Given this list of marker genes SAE1, TESK2, PDCD2, HGFAC, RPS23, RFK, HOXD9, TUBA1A, RUNDC3B, IL27RA, CACYBP, CARD14, SNCAIP, FUZ, GPR173, CCDC51, DCHS2, KCNC4, FAM32A, OGFOD2, DHCR7, IGF2BP3, PPP1R14D, SLC34A1, TMEM59, TRAF3, ELOA2, INPP5J, APOB, MAP7, PDCD1LG2 (NCBI Gene Id 80380), GBA1LP, INTS11, KCNC1, SRPK3, CPN1, SH2D4A, CNNM1, B3GNT3, ERH, MAT1A, PLA2G4C, EDNRB, VDR, CFI, GZMH, GNPDA1, JUP, WDR82, MYH7, HYAL4, TRIM31, GARNL3, DIS3, ACSBG1, GNAL, WDHD1, HMGA2, OPLAH, IFITM2, HNF4G, BIRC7, RAB9A (NCBI Gene Id 9367), SMIM10L1, PPARG, MTFR1, PROP1, MNAT1, DDX23, NUP42, POU3F2, ATP9B, USP4, ZFTRAF1, TMEM87A, PNKP, PMS2P11, RNASEL, STRN, GUCY1A2, NRG2, VTCN1, KLK5 (NCBI Gene Id 25818), GFPT2, POLR2G, LRRC20, NARS2, ITM2A, CFLAR, PARP11, BMP7, RAB3D, HOPX, SLC6A12, FLVCR2, PGLYRP4, RLBP1, DTNB (NCBI Gene Id 1838), AGT, ENPP2, CST4, PKLR, MECP2, RAB40A, CRYBA1, SULT1A2, CLPX, UVRAG, ANP32CP, KCNV1, KCNJ6, CPSF6, RAD51D, TIMM17A, NODAL, LMO2, NEFH, ZBTB20, ZNF446, SEZ6L2, IGF2-AS, XRCC4, AMT, CDK1, MFSD1, INTS7, POLR1HASP, TENM1, ZMYM5, PITPNM3, MORF4L1, PRKG1, TMBIM4, PIGF, GADD45B, DCSTAMP, CDK6, BOK (NCBI Gene Id 84558), DPY19L2P2, PTGER3 (NCBI Gene Id 5733), KIAA0040, FOXN1, C11orf68, AKR1A1, PPP1R13L, FCN2, NOC3L, COL4A5, MTOR, CHST2, LY75, SH3GL3, LIPA, C3AR1, DIPK1A, CEND1, KCNN1, FNBP1L, BTG3, AP1S2, CSNK2B, RBPJ, B9D2, TTLL7, TMPRSS15, TCN1, ERC2-IT1, SGSM2, KCNK1, SLC33A1, MAN2B2, EMD, ANKRD36BP2, IFT70A, COPB1, COL16A1, CYP2W1, RETSAT, ATP10D, TRHR, NES, LRRFIP2 (LRR binding FLII interacting protein 2), PCSK6, IFNG, ASB6, MYL1, THRB, KLK1, S100A11, CLIP1, NMUR1, IL12A, ABCA6, CNMD, CYP3A43, STRA6, here is a description of the gene set: from publication Nakaya HI, Wrammert J, Lee EK, Racioppi L, Marie-Kunze S, Haining WN, Means AR, Kasturi SP, Khan N, Li GM, McCausland M, Kanchan V, Kokko KE, Li S, Elbein R, Mehta AK, Aderem A, Subbarao K, Ahmed R, Pulendran B (PMID 21743478) studied in species Homo sapiens Genes down-regulated in comparison of myeloid dendritic cells from LAIV influenza vaccinee at day 7 post-vaccination vesus those from TIV influenza vaccinee at day 7. Systems vaccinology has emerged as an interdisciplinary field that combines systems wide measurements and network and predictive modeling applied to vaccinology. Here we used the systems vaccinology approach to study the molecular mechanisms underlying th Human Gene Set: GSE29618_LAIV_VS_TIV_FLU_VACCINE_DAY7_MDC_DN